The following is a description of a gene set: studied in species Homo sapiens Human Gene Set: GOBP_POSITIVE_REGULATION_OF_EPITHELIAL_CELL_PROLIFERATION Any process that activates or increases the rate or extent of epithelial cell proliferation., and this is the list of marker genes: CLDN1, EMC10, IRS2, NF1, FOXP2, CYP7B1, PDGFB, ACVRL1, HMGB1, SP1, HAS2, IHH, NKX2-6, HMGA2, PTPRN, KDR, STAT5A, EGFL7, EXTL3, PRKCA, RTN4, REG3G, MIR101-1, NME1, FGFR1, FGF9, ANG, EGF, EYA1, FOXE3, APELA, CCL24, STXBP4, FZD7, CXCL12, HDAC6 (NCBI Gene Id 100820762), NRP1, MIR23A, B4GALT1, RPTOR, CDH3, MYCN, GHSR, PDX1, HLX, PTN, LAMC1, ODAM, MTA3, MIR126, SOX9, GATA2, SOX11, BMPR1A, AKT1, SIRT6, CDH13, C5AR1, POLD4 (DNA polymerase delta 4, accessory subunit), MIRLET7B, PROK1, ERBB3, HMOX1, MIR29A, KDM5B, TGFB1, ERBB4 (erb-b2 receptor tyrosine kinase 4), EPGN, CDC42, GPBAR1, IL10, MIR503, FGF1, CCL5, PRKD2, FGFR2, MIR130A, PDCD6, VEGFB, CCL26, NR4A3, APLNR, CYBA, ERBB2 (NCBI Gene Id 2064), TEK, GRN, NODAL, F3, FGF7, CFLAR, CCR3, MIR499A, VEGFC, NR4A1, IQGAP3, ITGB3, LRG1, CCL11 (C-C motif chemokine ligand 11), SAAL1, SEMA5A, PAX2, NEAT1, FLT4, THBS4, AGGF1, YAP1, EGR3 (early growth response 3), AGTR1, RBPJ, SCN5A, SIRT1, JCAD, SCG2, PLCG1 (NCBI Gene Id 5335), OSR2, NOTCH1, MIR146A (microRNA 146a), HIF1A, APLN, MIR10B, TNFSF12, TNFAIP3 (NCBI Gene Id 7128), SCAND3, MIR487B, CRNN, NRARP, SHH, WNT3A, STAT3, CTNNB1, ZNF304, TACR1, DLX6, JAML, HSPG2, FGF10, MIR10A, MIR27B, TP63, TNF, CAV2 (caveolin 2), TCF7L2, BMP4 (NCBI Gene Id 652), ESRP2, MIR27A (microRNA 27a), HMGB2, TGFBR1, TGFA, MYC, ST8SIA1, SRSF6, REG3A, ECM1, IGF2, LACRT, VEGFA, ADAM17, ZNF703, XBP1, AKT3, VASH2, NME2, MIR21, IGF1, DLX5, WNT2, PKHD1, NRAS, WNT5A, PLXNB3, HMX2 (NCBI Gene Id 387716), WNT7A, LAMB1, AR, PIK3CD, PRKD1, MED1, NOD2, NUS1, WDR48, HRAS, BMP5, AREG, PROX1, PDCL3, PPP1R16B, ITGA4, ZNF580, NOTCH2, HPN, CCND1, MMP12, RUNX2, JUN, MDK, FGFBP1, BTK, NKX2-5, SMO, MYDGF, BAD, MIR495, MIR135B, BMP6, EGFR, OSR1, ITGB3BP, NRP2, TGM1, FGF2, TBX1, GDF2, PDPK1, RREB1 (NCBI Gene Id 6239), NOG, RICTOR, GHRL, MAP2K5, HTR2B, MIR132, ARNT